The following is a description of a gene set: from publication Yevshin I, Sharipov R, Kolmykov S, Kondrakhin Y, Kolpakov F (PMID 30445619) Genes containing one or more binding sites for (ZBTB18) in their promoter regions (TSS -1000,+100 bp) as identified by GTRD version 20.06 ChIP-seq harmonization. species: Homo sapiens Human Gene Set: ZBTB18_TARGET_GENES, and this is the list of marker genes: HS3ST3B1, FABP3, CNIH3, NUP133, STK19, UQCC6, RPL36, PTPN1, GALT, TRIM47 (NCBI Gene Id 91107), IFT70B, PPP2R5C, ZNF33B, NAPRT, LINC01145, MFSD4A, GGNBP2, ABI2, GCNT2, ZNF233, NEAT1, NSMCE2, ENSG00000266313, HMG20A, DHRS3, OST4, ZNF146, RAB34, ANKRD18B, WBP11, WDR70, DRG2, MT-ND6, ZMYND8, MIR3190, OGG1, DNAJC25-GNG10, BRMS1, SNORA80D (small nucleolar RNA, H/ACA box 80D), EPCIP-AS1, PARL, NPLOC4, NUCKS1, MAPK14, CAND2 (NCBI Gene Id 23066), RHBDF1, KDM8, LMAN2, ATP5MF, MMP25, ARHGAP4, MT-TY, APBA3, RGS9, TRAPPC3, PSMG1, PTBP1, TBL3, C14orf93, RAB1B, PPM1J-DT, BLACAT1, STK16, KCNJ2-AS1, GDAP2, RAD54L, LHX6, IKBIP, ENSG00000237813, TSKU-AS1, HARBI1, SLC39A8, C19orf38, VEZF1, ZNF287, SLC35D1, MGAT4A, KLHDC4, BICRAL, MRPL38, LINC02980, SEC31A, SEC22B, KDM4B, PPOX, SMAP1, STRA6, TGFB3, MIR4727, C6orf52, BBS4, AP4B1 (NCBI Gene Id 10717), NFX1, ZNF26, TCF12, ACTN3, PCYOX1, ZSCAN31, HCG9, ANXA2R, RPS15A, MTUS1-DT, GORASP1, CHAC1, SEPTIN9, PSD4, LINC00355, PTPRD-DT, TMEM200C, COMMD1, C1QTNF1, EGFEM1P (EGF like and EMI domain containing 1, pseudogene), PEAK1, PIP4P2, COL16A1, MT-TC, MT-TN, RBM34, ENSG00000268129, SRRT, ZDHHC24, VPS28, CDIPTOSP, KXD1, NKAPP1, SLC25A30, CA11, LOXL1, SNAI2, MED9, SPRED2, DHX30, MED27, KCNS3, LINC02985 (NCBI Gene Id 100508149), SKA1, RUNDC3A, NCOR2, S100PBP (S100P binding protein), HMGN3, MTND5P11, PRR3, LINC02593, MMADHC, LRRC40, MAP3K8, GPBP1L1, MPST, SSBP2, HDGF, SRSF11, PITX3, TMED1, C5AR1, UGP2, ZNF280D, NTRK2, LRRC1, MEX3B, TOMM40, GOLPH3-DT, GAD1, NCKAP5L, AXL, MEGF10, SPCS1, PSD3, SEZ6L2, KCNMA1, ZNF226, TRAPPC6A, COPS4, VAT1, INTS6, ERCC1, KRBA2, CRABP2 (cellular retinoic acid binding protein 2), CNOT10, DYNLRB1, ASPHD1, EDEM1, CREBL2, LRRC8C-DT, TATDN2, PISD, SGK3, TRPC1, CFAP298-TCP10L, ZNF829, MIR4453HG (MIR4453 host gene), ADRA1A, DLEU2, DDHD1, SLC27A3, TBC1D16, PCNX4, DENND1B, XKR4, GTPBP3, LRR1, PCSK6, TNFRSF19, SNF8, CDCA5, STEAP1, TGFBR2, MPP1, LSM3, KCNA5, IDH1, MRPL34, USP48, ORC6, ANAPC10, DDX11-AS1, MAN2A2, HIGD2B, ZNF331, CDKN1A, SVOP, NDUFAF3, MT-TE, PCSK6-AS1, CARHSP1, NUP133-DT, GNL1, SPRY4-AS1, UBAC2-AS1, FUNDC2, IFFO2 (NCBI Gene Id 126917), GPR12, SYCE2, GCC2, AHCY, USP32, RPS29, RPRD1B, PPM1J, LINC00869, PSMC3, METTL15, DDX54, GCNT1, CBX7, GINS3, PTCD1, JAKMIP2, COL7A1, PIKFYVE, HSBP1, ZBTB1, S1PR2, EPOR, BRPF1, TP53I13, ATG5, SON, NRM, ATP6V0A2, FGFR1, ZNF37A, KLF13, AFF4, MVP-DT, HP1BP3, NFATC4, ZDHHC13, TLK2, BCDIN3D-AS1, NDUFAF6, CCDC77, MRPL4, PHF21A, YARS1, MAP7D1, CENPT, LDHB, PARN, VWC2L, REXO2 (RNA exonuclease 2), LNCATV, DLC1, MAP2K4, SPG11 (NCBI Gene Id 80208), HNRNPD-DT, NFE2L2, RSRP1, FCHO2, TARS2, MIR191, SREK1IP1, PELP1-DT, MGAT4B, C1orf116, PSMD3, MTCO3P12, TAMALIN, ADGRB2, PRKCB, SDE2, ZNF133, ZDHHC22, RBL1, ENPP3, TMTC1, LDAH, PRPSAP2, PSMG4, GPRC5A, SERTAD2, SCP2, ZNF514, NID2, DNAI3, ACCSLP1, NEO1, CERT1, UBA52, LNX2, TPM4, DNM3, KDM5A, PLEKHH1, WDR20, CHST11, GEMIN8P4, RUNX2, RNVU1-2, COX16, VGLL4, SLC25A51, TSKU, DNAJB2, HNRNPH3 (NCBI Gene Id 3189), PAXBP1, NBL1, ITGB3BP, DUSP14, RIPK1, MT-TA, GREM2, AHNAK, OGDH, TTI1, ZBTB18, PCNX4-DT (PCNX4 divergent transcript), SEC63, NKAIN2, S100A2, RPGRIP1L, SPOCK2, RANBP2, CWC27, ZNF653, TGIF1, TLE6, PIGL, UBE2G1, ENSG00000237429, VGLL3, MRPS15, C11orf65, FBXW7, ATP10D, AGBL5, ORMDL3, MAP3K11, CHCHD2P1, LMNTD1, MYO1C, USF2, TTC39B, PCOLCE, ACBD4, BBIP1, ENSG00000215156, FKBP1A, ZNF654, POLR2K, CCSAP, KICS2 (NCBI Gene Id 144577), CACNA1C, MBIP, ANO8, ARMC8, PRMT9, NDST1, STOX2, MXD3, RNU6-2, ORC3 (NCBI Gene Id 23595, origin recognition complex subunit 3), DDX51, SPRYD4, KEAP1, ZFYVE19, PXDN, EPB41L3, CFAP298, MCC, PLEKHG2, RCAN1, LBX1, TMBIM4, ARHGAP45, HOXD8, RRBP1, RND3, ERI2, ATXN2-AS, APAF1, ZNF79, ATXN2 (NCBI Gene Id 8095), PELP1, TRIM62, INKA1, FBXL15, PLA2G15 (NCBI Gene Id 23659), STXBP6, NDE1, MIR425, ZNF224, TAF5L, PTPN6, ZFAND1, TRPV2, TMEM259, YTHDF2, MTUS1, AMDHD1, DMKN, CETN4P, CCDC88A, GUSBP18, RPS19, HSD11B1L, LOXL1-AS1, CHMP4C, DNMT1, BROX, NDUFA4, ZNF383, LYRM1, TST, CWC25, ANKRD49, CMSS1, HJV, PHAX, BRCA1, PDE10A, CFAP96, TSC22D1, ZC3H18, ST8SIA1, DAXX, TMEM69, TUBG1, NIBAN3, ST7 (NCBI Gene Id 93655), TRIM56, MRRF, NEURL1, ZFPL1, DLL3, DDIT4, RPL27, HOXD11, STKLD1, ALOX5, DEF8, APBB2, ZNF451, RARS2, NTN3, ADNP, RABAC1, NALT1, AP1G1, CPNE8, GLT8D2, TMEM45A, MORF4L1, PPCS, CHCT1, LRRC37A5P, PPP1R37, GGPS1, PDCD10, CBLN3, AGPAT3, BACH1, HNRNPH2, SLC43A2, NEUROG3, CCNL1, CHEK2, SMARCE1, DIRC3, CCDC38, RPSAP31, HERC5, ARHGAP12, SNX18, PHB1, LRPPRC, TRMT61B, HM13-AS1, CTTNBP2, AP2S1, GTF3C2, H3P32, ATP5MF-PTCD1, BLOC1S3, TBP (TATA-box binding protein), SP7 (NCBI Gene Id 121340), PCNP, MAPK8, CNIH3-AS2, TRAFD1, GPI, PRTG, SAT2, RPL36AL, FBXW5, NUP153 (NCBI Gene Id 9972), ZNF341-AS1, HOOK2, FRMD4B, MIR5695, HNRNPD, BCL2L13, ACVR1, FOXP2, CRKL, SLF2, MAPKAPK5-AS1, RBM18, LINC01227, AIDA, TMEM250, PTPRF, PEDS1, MAPKAPK5, HSF2BP, LINC01275, SERPINI1 (serpin family I member 1), TRMT2A, EIF3H, TEDC2-AS1, CARHSP1-DT, WIZ, MLST8, ATG13, SUCO, SREBF2, ZNF2 (zinc finger protein 2), TUBG2 (tubulin gamma 2), ANKS1B, SLCO3A1, ATP8B2, NOLC1, CCDC33, AKAP10, GPR180, TSPAN13, MET, RPA3, SERTAD4BP, CACNA1G, LINC02846, CRTC2, KPNA6, RNVU1-27, PEDS1-UBE2V1, COQ8B, GFRA3 (GDNF family receptor alpha 3), ERCC5, MRPL20, ENSG00000247416, PIAS1, MATCAP2, POMT2, TMEM123, DTD1, HNRNPLL, RRP1B, SETD1A, GPAM, TSC22D4, REXO5, JPX, BDKRB2 (NCBI Gene Id 624), SARAF, BBS12, PRDM10, RAB4B, HCFC2, PDE5A, GTF3C2-AS2, AKAP1-DT, ZDHHC9, WDR4, WDR13, MT-ND4, MIR4674 (microRNA 4674), NAT10 (N-acetyltransferase 10), ZNF589, RCC2, ZNF131, CDH13-AS2, DCUN1D3, POLR3G, ATAD3A, GAN, LINC00602, RABGAP1L-DT, RFC1, TMEM134, HNRNPL (NCBI Gene Id 91538), SKIC3, SIX5, F3, ANKRD13A, ALDH1A2, TAF11, CCT8, MDM2, IQGAP2, HDAC6, UNC13D, PLAUR, POLK, TMCC3, PCNX3, FTH1, NDUFB7, TMEM14C, CD9, GCHFR, MIA3, WDR7, L3MBTL1, STAT1 (signal transducer and activator of transcription 1), PIAS3, TMEM91 (NCBI Gene Id 641649), HCG25, ARF6, NOTCH1, SHBG (sex hormone binding globulin), TRIM52-AS1, GLB1L, ZNF565, MIR22HG, ZMYND12, IFT56, NR2C1 (NCBI Gene Id 7181), PSMB1, TRGV7, LTBP4, MIR1284, TNC, RAB4B-EGLN2, GLI3, ENTPD1-AS1, WASHC5, MED23, PLD1, CBX5, DCLRE1B (DNA cross-link repair 1B), TFAP4, PLSCR1, HSCB, NDUFV3 (NADH:ubiquinone oxidoreductase subunit V3), APTX, NUP214, LASP1, NOC4L (nucleolar complex associated 4 homolog), C8G, TSPAN9, POLR1D, PSD, GARS1, PTPRD, CDK5R2, FCHO2-DT, LINC00680, MICOS13, GAMT, ARHGEF10, A2M-AS1, GARS1-DT, STON2, DHRS4-AS1, SULF2, CDADC1, ZBTB12, CCDC159, FDXR, BCAN-AS2, MT-TT, ITGA5, NEK2, AKT1, CDIPT (CDP-diacylglycerol--inositol 3-phosphatidyltransferase), U2SURP (U2 snRNP associated SURP domain containing), GPBP1, TIMM50, MT-CYB, DEDD, PIP4P1, CIROP, FBXW9 (F-box and WD repeat domain containing 9), ZNF23, BIRC6, PHKA2, SHOC2, GLA, GLRX3, LETM1, RNVU1-23, LSM5, ANLN, UFSP2, TXNL1, TRIM52, ASGR1, SEMA6A, NAGLU, MCTP1, AFF4-DT, STX11, VXN, ZNF568, TOMM6, RNH1 (NCBI Gene Id 6050), SPRY4, NCAM1, NBR2, GBA1, MPG, PGD, SERTAD3-AS1, ABCE1, GSTZ1, MRPL54, PFKFB3-AS1, SV2A, RNF43, TYSND1, CENATAC, PRDM2, TGFB1, NBPF12, NOL10, SSBP3P1, CYGB, RN7SKP11, ZBTB25, APC, UBA1, CRYBG1, DXO, WFDC21P, PRKAA1, FTO, ADAMTS6, SERTAD3, ZC3H12C, FOXN2, WRNIP1, TTLL7, DDX11, ADAMTS2, LINC01775, ZSWIM9, MYH9, CHMP4B, ARSK (NCBI Gene Id 153642), TPK1, MAFA, CCDC87, VWA3B, SOCS3-DT, CCT4, EMC7, AUTS2, ATF3, RECQL5, RANBP1, CEP170B, UTP23, KLHL12, UCP2, ZNF326, URB2, TTC21A, WDR3 (NCBI Gene Id 10885), DNAJC25, TACR1, RN7SL832P, DALRD3, ARID4B, CIC, SUSD4, CDKN2A, PPM1K-DT, PKN2, LINC02614, RAD18, PPM1K, PARP8, EMC4, SNRNP35, NUBPL, BET1, RANBP9, ABT1, PGBD4, SNW1, ATP2A3, EPHB4, MYOM1, TTC39A, MICALL1, NXPH3, RCOR2, ZMIZ2, PRIM2, PRDM4, ZZZ3, EMC3, SIRT6, ZNF585B, FIGN, NSG2, AKAP1, FGF12, F8, DNAJC17, INTS6-AS1, CDKN2B-AS1, MCCC2, LY6K, RPUSD2, SLC38A1, DENND4B, INO80D-AS1, EFCAB7, SLCO4A1-AS2, CCDC34, MARF1, NUBPL-DT, CCS, LIG1, CENATAC-DT, POP4, TBCC, RABGAP1L